The following is a description of a gene set: Subpopulations of human fetal thymocyte and circulating naïve T cells were obtained through FACS sorting, including CD3-CD4+CD8- intrathymic T progenitor cells (ITTP), CD3intCD4+CD8+ \double positive\ thymocytes (DP), CD3highCD4+CD8- \single positive\ thymocytes (SP4), CD3+CD4+CD8-CD45RA+CD62L+ naive T cells from cord blood (CB4+), and CD3+CD4+CD8-CD45RA+CD62L+ naive T cells from adult blood (AB4+). species: Homo sapiens from publication Lee MS, Hanspers K, Barker CS, Korn AP, McCune JM (PMID 15210650) Human Gene Set: GSE1460_DP_VS_CD4_THYMOCYTE_UP Genes up-regulated in comparison of CD4 CD8 thymocytes versus T cells from cord blood., and this is the list of marker genes: PSMA7, ALDH2, RIPK4 (receptor interacting serine/threonine kinase 4), LAIR1, GRPEL1, MAP2K2 (NCBI Gene Id 85511), PHLPP1, MARCKS, PEX5, SEC61A2, CD99, NPEPL1, EFNB2 (ephrin B2), RAPGEF5, HEMK1, DCTN3, RAB8A, FA2H, NEIL3, FBXL12, RNF141, WDR45, SRSF3, PSMA5, PSMB7, LAMB2, AEBP1, NUDT21, TBCD, SNRNP70, MZB1, MAP6D1, MCPH1, MPPE1, GNA15, BRD9, SLC25A3, PTCRA, NDUFV1, FSTL1, PON1, TNFRSF21, EAF2, SLC29A1, CHCHD7, UPF1, PEF1, GSE1, PCDH9, CXCR4, TMT1A, MTMR2, CD1E (CD1e molecule), BAZ2A, MYB, DPF2, DHTKD1, UIMC1, ENY2, ORAI2, LETM1, POLR2F, TEX10, PRMT7, TXN, PCBP2, TIMP2, PSMD4, GLT8D1, ZNF767P, CDK2AP2, H3C10, COASY, HACD1, CD72, EXTL1, ITIH4, ELOCP28, GCDH, CPVL, PNPLA4, FAF1, TBC1D1, AQP3, CD1B, OR7E47P, STMN1, MNS1, TBC1D19, FOXI1, GNPAT, RPL23AP7, H2AC8, PHLDA3, DNMBP, MAP1A, ASL, MAP2K6, CD38, PSMA3, NEIL1, MAGOH, GAB2, RPP30 (ribonuclease P/MRP subunit p30), GABRB3, GFI1, RALGPS1, PPM1G, TESMIN, CORO2A, UCK2, RAD51C, GPR19, CSNK2B, THYN1, DHX8 (DEAH-box helicase 8), NDUFS6 (NCBI Gene Id 4726), FECH, LCT, PAF1, SERPINI1, WDR19, FBXO7, TSPAN9, VOPP1, PRDX6, PTPRM, PLPP3, COX17, SMIM8, CASK, AATF (NCBI Gene Id 26574), PSMD9, ACSBG1, HMGB1, VRK1, REXO5, CDKN2C, IFT46, ARPP21 (NCBI Gene Id 51183), PLCB4, PLK4, XBP1, KCNK15-AS1 (KCNK15 and WISP2 antisense RNA 1), SEC13, CGGBP1, LDLRAD4, ARHGAP19, JAKMIP2, NAPG, FXYD6, ASF1A, AAMDC, ECI1, UTP11 (NCBI Gene Id 51118), ANKHD1 (ankyrin repeat and KH domain containing 1), CTNNBL1, GUCY1B1, FAM216A (NCBI Gene Id 29902), ARL4A, SAP130, JAG1, SCRN1, MRPS22 (mitochondrial ribosomal protein S22), LRRC1, RPL39L, SH3TC1, MKRN2, CEMP1, STN1, MCM10, CLIC1, FAIM, MDC1, MITF, NIF3L1, DGKE, PPP2R2D, RHOT2, AGK, ITGB1BP2, PLXND1, ARHGEF7, NUDC, TSHR, FRZB, CD1C, SPSB3, SKIC2, RAG1, HERC2, OSBPL9, DAPK1, CTC1, MPP1, STAG3, CD1D, CD8B, ACYP1, CHRNA3